The following is a description of a gene set: part of: Degradation of cysteine and homocysteine electronically inferred by orthology from the curated human pathway studied in species Mus musculus Reactome Pathway: Sulfide oxidation to sulfate This event has been computationally inferred from an event that has been demonstrated in another species.<p>The inference is based on the homology mapping from PANTHER. Briefly, reactions for which all involved PhysicalEntities (in input, output and catalyst) have a mapped orthologue/paralogue (for complexes at least 75% of components must have a mapping) are inferred to the other species., and this is the list of marker genes: Suox, Ethe1, Slc25a10